The following is a description of a gene set: studied in species Mus musculus Mouse Gene Set: REACTOME_HDACS_DEACETYLATE_HISTONES HDACs deacetylate histones, and this is the list of marker genes: H2bc6 (H2B clustered histone 6), Mta2, Hmg20b, Brms1, Hdac8, H3c14, H4c1, Mta1, H3c2, H2aj, H4c14, Chd3, Hdac10, Hdac1, H4c8, H2ac8, H4c12, H2bc3, H4c17, H3c4, Gatad2a, H4c11, H2bc22, H3c7, H2ac13, Gps2, H4c2, H3c3, H2ac20, H3c8, H2bc1, H2ac12, H4c6, H3c15, H2ac4, Arid4a, H2bc21, Tbl1x, H2bc11, H2bc26, Kdm1a, H3c13, Mbd3, H2ac19, H3c1 (H3 clustered histone 1), H2ac11, Hdac3, H2ac1, H4c3, Chd4, H2ac23, Arid4b, Rest, H4c4, H2bc23, H2bc9, H3c6, Rbbp4, Sap30l, H2ac24, Rcor1, H2ac10, H2bc13, Gatad2b, H2bc24, H3c10, H2bc8 (H2B clustered histone 8), H2ac6, H2ac18, H2bc7, Mta3, Rbbp7, Phf21a, H2bc12, H2ac21, H2bc18, H3c11 (H3 clustered histone 11), Suds3, H4c18, H2bc15, H2ac15, H2bc14, H2ac7, Tbl1xr1, H2ac25, Ncor2 (NCBI Gene Id 20602), Sap30, H4c9, H4c16 (NCBI Gene Id 674678), H2ac22, H2bc4